The following is a description of a gene set: from publication Myllykangas S, Himberg J, Böhling T, Nagy B, Hollmén J, Knuutila S (PMID 16751803) studied in species Homo sapiens Human Gene Set: MYLLYKANGAS_AMPLIFICATION_HOT_SPOT_8 Amplification hot spot 8: colocolized fragile sites and cancer genes in the 9q11-34 region. DNA copy number amplifications activate oncogenes and are hallmarks of nearly all advanced tumors. Amplified genes represent attractive targets for therapy, diagnostics and prognostics. To investigate DNA amplifications in different neoplasms, we performed a bibliomics survey using 838 published chromosomal comparative genomic hybridization studies and collected amplification data at chromosome band resolution from more than 4500 cases. Amplification profiles were determined for 73 distinct neoplasms. Neoplasms were clustered according to the amplification profiles, and frequently amplified chromosomal loci (amplification hot spots) were identified using computational modeling. To investigate the site specificity and mechanisms of gene amplifications, colocalization of amplification hot spots, cancer genes, fragile sites, virus integration sites and gene size cohorts were tested in a statistical framework. Amplification-based clustering demonstrated that cancers with similar etiology, cell-of-origin or topographical location have a tendency to obtain convergent amplification profiles. The identified amplification hot spots were colocalized with the known fragile sites, cancer genes and virus integration sites, but global statistical significance could not be ascertained. Large genes were significantly overrepresented on the fragile sites and the reported amplification hot spots. These findings indicate that amplifications are selected in the cancer tissue environment according to the qualitative traits and localization of cancer genes., and this is the list of marker genes: PTCH1, FNBP1, ABL1, XPA, TSC1, CNTRL, TAL2, NUP214, SYK, NR4A3, SET (SET nuclear proto-oncogene), FANCC